The following is a description of a gene set: species: Homo sapiens A cell surface receptor signaling pathway in which ligand binding causes the receptor to dimerize, bringing the receptor-associated JAKs into close proximity. The JAKs then phosphorylate and activate each other on tyrosine residues.This leads to the activation of associated STAT protein, causing the STATs to dissociate from the receptor, translocate to the nucleus. The pathway ends with regulation of target gene expression by STAT proteins. Human Gene Set: GOBP_CELL_SURFACE_RECEPTOR_SIGNALING_PATHWAY_VIA_JAK_STAT, and this is the list of marker genes: ERBB4, IFNL3, IL15, STAMBP, ADIPOR1, STAT1, IFNB1, OCIAD2, IFNL1, EPHB2, CSF1R, IL15RA, SOCS6, CCL2, IL12A, SOCS5, IL23R, PKD2, CENPJ, PKD1, ELP2, IL26, INPP5F, TYK2, TSLP, GHR, PTPRC, PIAS1, CD40, IL12B, CTF1, IL7R, DAB1, NMI, ERCC6, CSH1, IL9, BCL3 (NCBI Gene Id 602), F2, CAV1, CSF2, PTPN2, CNTF, LEPROT, CSHL1, TNFRSF18, STAT2, IL10RB, PTPRD, FLT3, HMGA2, CLCF1, STAT5B, IL10, EGF, IFNAR2, WDR48, CSH2, IFNAR1, TNF, HGS, GBP7, JAK2, SOCS2, SOCS3, PTK6, TNFRSF1A, JAK1, CYP1B1 (NCBI Gene Id 1545), SOCS1 (suppressor of cytokine signaling 1), RAC1, STAT3, OCIAD1, IL20, CSF2RA (NCBI Gene Id 8282), PRLR, IL31RA, OSM, CTR9, NOTCH1, GH2, HES1, CSF2RB, IL18, MIR221, FGFR3, USP1, CAMK2A, MST1, STAT6, KIT, LEP, FER (NCBI Gene Id 2241), JAK3, IL4, IL6, CCR2, VHL, CNOT7, IFNL2, PIBF1, IFNL4, CALM1, IL5, PRL, IFNG, PTK2B, NEUROD1, MST1L, PARP9, TNFSF18, EP300, GADD45A, SH2B3, IL21, MIR9-1, IL10RA, ARL2BP (ADP ribosylation factor like GTPase 2 binding protein), CISH, DOT1L, STAT4, F2R, IL23A, STAT5A, MIR146A, PIGU, CRLF3, GH1, NF2, PARP14, HES5